The following is a description of a gene set: The myofibril assembly process that results in the organization of muscle actomyosin into sarcomeres. The sarcomere is the repeating unit of a myofibril in a muscle cell, composed of an array of overlapping thick and thin filaments between two adjacent Z discs. Human Gene Set: GOBP_SARCOMERE_ORGANIZATION species: Homo sapiens, and this is the list of marker genes: ANKRD23, CAPN3, CASQ1, MYBPC1, TCAP, CSRP3, MYOM1, WDR1, TNNT3, FHOD3, MYBPC2, TNNT1, CSRP1, CFL2, MYH6 (NCBI Gene Id 4624), ITGB1, FLII, KRT19, CAV3, MYLK3, PROX1, MIR1-1, MYOZ2 (NCBI Gene Id 53348), PRKAR1A, MYBPH, MYOZ1, ACTN2, MYOM3, ANKRD1, MYH3, SYNPO2L, ACTG1, LDB3, PRKD1, SIX4, TPM1, EDN1, FLNC, PLEC, TTN, TNNT2, MYPN (myopalladin), MYBPC3, CSRP2, LMOD2 (leiomodin 2), MYOM2, OBSCN, AKAP13, SRF, BMP10